The following is a description of a gene set: species: Mus musculus Any process that stops, prevents, or reduces the frequency, rate or extent of the phosphorylation of peptidyl-serine. Mouse Gene Set: GOBP_NEGATIVE_REGULATION_OF_PEPTIDYL_SERINE_PHOSPHORYLATION, and this is the list of marker genes: Gadd45a, Nck1, Grk2, Epm2a, Rassf2, Inpp5f, Gpd1l, Rack1, Bdkrb2 (bradykinin receptor, beta 2), Ogt, Bax, Smad7, Inpp5k, Dmtn, Cav1, Paqr3, Mlxipl, Dkk1, Hgf, Pten, Inpp5j, Cnksr3, Ppm1f, Bak1